The following is a description of a gene set: Reactome Pathway: Reproduction Human reproduction mixes the genomes of two individuals, creating a new organism. The offspring individuals produced by sexual reproduction differ from their parents and from their siblings. Reproduction includes the reproductive system, sperm and egg production (haploid cells), fertilization, and the early stages embryo development. studied in species Homo sapiens, and this is the list of marker genes: RAD50, RPA2 (NCBI Gene Id 6118, replication protein A2), H2BC14, BRCA1, H3-3A, MSH4, H2AC6, H2AC18, ATM, CD9, H2AJ, SYCP2, SYCE2, TERF2 (telomeric repeat binding factor 2), KCNU1, TERF2IP (NCBI Gene Id 54386), RPA1, EOMES, SPO11 (SPO11 initiator of meiotic double strand breaks, NCBI Gene Id 23626), SMC3, HSPA2, H2AZ2, H2BC5, H2AX, SUN2, REC8, H2BC12, OVGP1, MRE11, STAG2, RAD51, MSH5, IZUMO3, NANOG, STAG3, H2BC11, H4C1, CATSPER2, H2BC26, SYCE3, H2BC9, H2AC7, NBN, TFAP2C, ZP4, NANOS3, CATSPER4, DIDO1, HVCN1, H3-4, ATR, CATSPERD, H2BC4, MLH1, IZUMO4, LMNB1, CATSPER3, ACR (acrosin), CATSPERB, PSMC3IP, CATSPERG, H2BC12L, CBFA2T2, TOP3A, H2BC3, ADAM30, UBE2I, SOX17, H2AB1, ADAM20 (NCBI Gene Id 8748), SMC1B, H2AC14, H2BC17, IZUMO1, H2BC13, ADAM2, PRDM1, SYCE1, FKBP6, POU5F1 (NCBI Gene Id 7934), SYCP3, POT1, MND1, RPA3, B4GALT1, BMP4, H2AC20, FIGNL1, TEX15, TERF1, BLM, RBBP8, FIRRM, BRCA2, H2AC4, SPAM1, SYNE2, STAG1, H2BC15, CATSPER1, ZP1, PRDM9, RAD51C, SUN1, ZP2, H2BC1, SYNE1, PDPN, TEX12, LMNA, TINF2, TET2, DMC1, H2BC21, ACD, MLH3, ZP3, SYCP1, H3C15, ADAM21, H3C1, CDK4, CDK2, IZUMO2, SMC1A, CXCR4, RAD21